Given this list of marker genes ARX, MEGF8, KRT83, CUL7, LMBRD2, BICRA, HYLS1 (HYLS1 centriolar and ciliogenesis associated), KAT6A, SV2A, PLXNA1, BBS5, MKS1, TRRAP, RBM10, SLC9A6, AMMECR1, DNAJC21, ANKRD11, RALGAPA1, JUP, COX7B, DKC1 (dyskerin pseudouridine synthase 1), CCDC47 (coiled-coil domain containing 47), KMT2D, EHMT1, CDSN (NCBI Gene Id 56798), ECEL1, MAPK1, TGDS, RAG2, ARID2, MAP2K1, KDM6A, TMEM94, PEX1, LPAR6, PURA, AXIN2, IFT74, SPOP, DCLRE1C, PHIP, CCNK, ASH1L, PLAA, SMARCA4, PQBP1, PEX6, CNTNAP2, CTCF, AEBP1, KCNMA1, KATNB1, WAC, CNOT2, PIGS, SLC29A3, PACS2, LAS1L, ANTXR1, KREMEN1, OCA2, MGAT2, NFIX, LIG4, STXBP1, IL2RG (interleukin 2 receptor subunit gamma), SULT2B1, CLCN3, MEIS2, MED12L (mediator complex subunit 12L), NANS, TMEM147, COG6, SMC1A, LMNA, DPH1, ITGB6, SIAH1, OTX2, TCTN3, CDC42 (NCBI Gene Id 998), NF1, RALA, CBL, CEP120, ZMPSTE24, VPS35L, PHF8, TTC7A, RET, MED12, DLX4, HGSNAT, UGDH, UBE4B, MBD5, LZTFL1, ATAD3A, KRT81, MASP1, WLS, CDK19, SCLT1 (NCBI Gene Id 132320), NBAS, VAC14, CEP19, PPP1R15B, AIFM1 (NCBI Gene Id 9131), RPS28 (NCBI Gene Id 6234), FBXO31, LRP1, OTUD6B, FAR1, ODC1, BBS12 (NCBI Gene Id 166379), SGSH, HECW2, WRAP53 (NCBI Gene Id 55135), NPHP1, ZFX, NRAS, TRMT1, SDR9C7 (NCBI Gene Id 121214), IDUA, MAGEL2, SF3B4, MAPK8IP3, MTX2, GUSB, EGFR, UFC1, KCNJ8, HR, PHF6, KRAS, NAA10, KDM5C, ARL6, PSMC3, NCAPG2, SMPD4, TCTN1, TOGARAM1, EIF4A2 (NCBI Gene Id 63124), ASPRV1, ADAT3, DSC3, FUCA1, NHP2, BBS9, SCARF2, HRURF (NCBI Gene Id 50823), B9D2, RNF2, TRIO, AHDC1, KIAA0753, SOX11, MYO5A, POLR1A, DDX59, NFIB (NCBI Gene Id 4781), MAN1B1, CWF19L1, ZNF699, PCDHGC4, DEAF1, MBTPS2, CDON, SHMT2, TBL1XR1, SEMA3E, SPRED2, ARID1B, KCNK4, DNA2, BBIP1, TP63, GJA1, CDH2, POGZ, RPS6KA3, CHD8, KCNN3, MC1R, MKKS, EPS8L3, NELFA, DDX6, EBF3, OGT, FGFR1, RIPK4, PDPN, SOX4, DNMT3A, ABCA12, EXT1, LTBP3, WDPCP, MMP23B, APCDD1, COL1A2, OBSL1, FOXL2, FLI1, MN1, KDM4B, LIPN, COL18A1, SLC35A2, KRT85, H4C11, TRAPPC10, LIPH, COLEC11, H4C5, FAS, ESAM, YY1, ASPM, FHL1, TFAP2B, NUP188, SETD5, LMX1B, AHSG, ARL3, IGF1R, NAGLU, TWIST2, INPP5E, MAPRE2, BCOR, EDA, TAF4, CASZ1, IQSEC2, UGP2, XYLT1, KCNH1, NEPRO, CLP1, MED25, RPGRIP1L (RPGRIP1 like), NIPAL4, CREBBP, PDE6D, ACTB, PI4KA, ADAMTS3, ERI1, H3-3A, PIGO, SLC1A4, ZNF407, MTHFS, MEF2C, DENND5A, LUZP1, EDARADD, RTEL1, SOS1, PARN, IL7R, FAM20C, SPEN, DOCK7 (NCBI Gene Id 85440), ABCC9, ZEB2, NUDT2, TRMT10A, LETM1, KNL1, ASXL3, RIN2, MED27, TUBGCP2, AFF3, TMEM218, CACNA1A, U2AF2, TERT, HNRNPU (heterogeneous nuclear ribonucleoprotein U), WNT4, SMARCD1, SHOC2, TALDO1, PACS1, RNU4-2, TFE3 (transcription factor binding to IGHM enhancer 3), KDM1A, MAP2K2, AIP, MITF, ARL13B, TMEM237, PIGG, ST14, WDR35, PPP1R21, TOE1, CHSY1, THUMPD1, TRPS1, SOX18, PIGW, FBXL4, STAG1, TBCD, SPECC1L, MAP3K7, RNU12, KRT25, ROBO1, HID1, FGFRL1, UBE2A, BCAS3, SETD2, SPTBN1, PTPRF, KRT71, RUSC2, MESD, PTCH1, TMEM216, GPRASP2, CSPP1, SETD1B, ADAM17, BCR, IL1RAPL1, CASP2, PLCB4, LTBP1, PRKD1, CEP290, PCNT, B3GAT3, SLC35C1, WARS1, APTX, RPL21, LTV1, ZBTB20, ARID1A, UQCC2, HNRNPH1, JARID2, TRIM8, AHI1, CLCN6, SNRPE, KIFBP, PIGY, CFAP418, CSNK2A1, HEATR3, UBR7, HIVEP2, CCDC8, COLEC10, SLC25A24, FAM149B1, SON, PRR12, PUM1, SMARCB1, HSPA9, ZMYND11, ERMARD, CHST3, HDAC8, PTPN22, PGAP1, KAT5, KCNAB2, SATB1, CYP4F22, TGM1, PRDM16, MAB21L1, UBE3B, SOS2, CEP41, TAF1, HERC1, FGF3, FBXO28, WNT10B (Wnt family member 10B), PUF60, PYCR2, DPH5, SLC39A4, PRKCZ, TOPORS (NCBI Gene Id 641432), DYM, BRAF, BANF1, RAD21, TRIM32, CPLX1, KMT2C (lysine methyltransferase 2C), ZNF423, ADA, PIGN, SMCHD1, CHMP1A, RAI1, PIGL, ATP1A3, BMP2, LRPPRC, TASP1, ZBTB18, NSUN2, ALOX12B, CEP104, SLC32A1, DSG4 (desmoglein 4), DEPDC5, ANAPC1, NPM1, BBS1, CHD6 (chromodomain helicase DNA binding protein 6), SCAPER, FRAS1, ATR, CTC1, TERC, NSD2, CRIPT, EBP, BCL11B, GJA8, RNF125, SPINK5, CDK10, MED13, MARS1, HBA2, H4C9, ZNF462, EDA2R, WDR26, AUTS2, AASS, SMOC1, CWC27, CHD1, ASXL2 (ASXL transcriptional regulator 2), AFG2A, HSPG2, GNE, COX5A, NIPBL, UBAP2L, TBCK, VPS33A, TCTN2, TMEM67, RECQL4, NOP10 (NOP10 ribonucleoprotein), CC2D2A, TMEM138, ZSWIM6, KDF1, IARS2, ATP6V1B2, CHD7, KIT, BPTF, RNF113A, ABL1, HDAC4, SETBP1, FRMD4A, KANK2, ELN, USB1, NOTCH2, GJB6, SUPT16H, BBS2, CBY1, GJB2, SMC3 (structural maintenance of chromosomes 3), HOXC13 (homeobox C13), SZT2, AARS1, STAG2 (NCBI Gene Id 10735), SOX6, MAF, MAN2C1, TMCO1, B9D1, CLDN1, CAMK2G, CYFIP2, FAM111B, TBX3, SUMF1, SMS (spermine synthase), RAP1GDS1, BBS4, GABRD, CEP295, RBL2, PRKG2, PUS7 (NCBI Gene Id 54517), FIG4, TAF6, SLC45A1, CPLANE1, CDC45, CDK13, SHANK3, KRT86, HEPHL1, WASHC4, PIGV, TYMS, KRT74, FOXP2, NEUROG1, STRADA, TTC8, DOLK, VPS13B, MLXIPL, CHRNA7, BRD4, ALX1, KIF26A, ACER3, ZNF711, NKX6-2, SMARCC2, CDC42BPB, PKP1, ACBD6, ERLIN2, CTU2, SCN4A, COL11A1, NDST1, ZIC2, IRX5, AFF4, ABCA5, KMT2A, MYCN (MYCN proto-oncogene, bHLH transcription factor), GNB2, KLF13, KIF7 (NCBI Gene Id 46), GTPBP2, SYT1, KATNIP (katanin interacting protein), SMARCE1, CASK, ZNF292, CRKL, MAPKAPK5, ASCC3, RAC1, DPF2, GAD1, NRCAM, MAP1B, FLII, SDCCAG8, ASXL1, TCF4, UROS, EIF5A, TRAPPC9, GABRA3, OFD1, PRRX1, CUL4B, EDAR, B4GALT7, DDX3X, NSD1, BBS7, NAA80, SLC6A17, RMRP, TMEM231, ATP1A2, DDB1, INTS1, PIBF1, EP300, GNPTAB, SUFU, RERE, RAB34, PAX3, EMC10, RNU4ATAC, RAG1 (recombination activating 1), KMT5B, SMAD4, ITGA3 (integrin subunit alpha 3), SIN3A, DHX30, BRF1, SKI, PPP1CB, PGAP2, IFT172, SLC4A10, ALOXE3, RAP1B, ALX4, EDNRB, CDH3, BBS10, ARMC9, PIGK, NECTIN1, ACTG1, TBX4, COL3A1, FRA10AC1, CHD5 (NCBI Gene Id 26139), HNRNPK, FBXO11, KIAA0586, POLR3A, HMGA2, HECTD4, FREM1, MADD, KCNK9, KRT17 (keratin 17), GNS, SNAI2, WNT10A, LEMD3, TTI2, DSP, PSMC1, SLC1A3, XYLT2, NMNAT1, CTBP1, LZTR1, C12orf57, PDCD6IP, RPS23, PGAP3, IFT27, HBA1, EDN3, CDKL5 (cyclin dependent kinase like 5), DPH2, LSS (NCBI Gene Id 4047), RAF1, TYRP1, PSMD12 (NCBI Gene Id 5718), MED13L, CERT1, SOX10, POLA1, ESCO2, FBN1, TTC5, SIM1, CRELD1, LARP7, SMARCA2, MAN2B1 (mannosidase alpha class 2B member 1), TINF2, CDH11, PPP2R3C, RHOBTB2, GPR101, GJA5 (NCBI Gene Id 2702), here is a description of the gene set: Abnormal eyebrow morphology An abnormality of the eyebrow. Human Gene Set: HP_ABNORMAL_EYEBROW_MORPHOLOGY studied in species Homo sapiens